The following is a description of a gene set: species: Homo sapiens Human Gene Set: HP_ECCHYMOSIS Ecchymosis A purpuric lesion that is larger than 1 cm in diameter., and this is the list of marker genes: ITGA2B, IFNG, COL3A1, MPL, TERT, JAK2, TET2, HPS1, STXBP2, NUMA1, RARA, USP48, IRF2BP2, PML, SBDS, STAT3, BRAF, NPM1, ITGA2, TP53, FIP1L1, CD109, GIMAP5, GP1BA, COL1A1, TBXA2R, ZBTB16, CDH23 (cadherin related 23), STX11, PLCG1, CALR, CHST14, GFI1B, GP1BB, COL5A2, F2, PRF1, NABP1, COL5A1, F13B, NR3C1, ITGB3, BCOR, GP6, PRKAR1A, F13A1, ATRX, AIP (NCBI Gene Id 9049), TBL1XR1, UNC13D, STAT5B, RUNX1, GGCX, P2RY12, USP8, GBA1, HPS6, TERC